Given this list of marker genes CGN, ARL8A, JMY (NCBI Gene Id 23651), MDM1, CLIP3, FTCD, KIF16B, TTLL6, KIF22, TTLL11, ARHGEF2, GAS2, DRG1, TTLL4, SPAG8, KLC3, MAP10, AGBL5, LRRK2, DNAL1, MAP9, MAPRE2, RGS14, TUBGCP6, TTLL9, HAUS8, FAM161A, FEZ1, WASH3P, MAP4K4, CEP350, TRIM36, APC, EML1 (EMAP like 1), ARL3, CCSER2, KIF14 (NCBI Gene Id 9928), KIF7, CFAP157, RPS3, KIF4A, MACF1, VPS41, DIP2B, IFT81, CHP1, KIF1B, KIF19, DNM1L, TTLL2, DNM3, AGTPBP1, EFHC1, MARK4, TUBGCP3, UNC5C, MAP7D2, KIF25, POLB, KIF3B, CCT5, TAOK1, HSPH1, TPPP2, CEP290 (centrosomal protein 290), BLOC1S2, MAST1, KIF26A, CENPE, CCDC187, APC2, SPIRE1, BRSK1, TTLL7, WDR90, CAMSAP3, TPGS1, DCTN1, NEIL2, KIF23, KIF21B, WHAMM, DLGAP5, ABRAXAS2, CCDC66, SSNA1, SGIP1, STMN4, NDRG1, RCC2, KIFC3, HAUS4, KIF20B, RP1, RMDN2, KIF4B, CCSAP, GABARAP, CEP57L1, CLIP2, RAD51D, KIF21A, AGBL1, TBCEL, MAP1B, SUN2, HDGF, CAPN6, ARL8B, MX2, SLC6A2, EML3, GJB6, CETN3, SKA1, NEFM, PHF6, FES (NCBI Gene Id 2242), TTLL13, RABGAP1, SPAG5, KATNBL1, GOLGA2, MTUS1, GAS2L3, EML2, TRPV4, KATNA1, FYN, HTT, GABARAPL1, APPL1, EMD, ZNF207, SPAST, FBXW11, TTLL1, WASH6P, CCDC61, FHDC1, KIF2A, VASH2, EML4 (EMAP like 4), CAMSAP1, KIF17 (NCBI Gene Id 57576), RANBP10 (NCBI Gene Id 57610), BRCA2, EML5, OPA1, GAS2L1, TPPP3, KIF27, BCL2L11, TTLL5, KIF1C, VAPA, DNM1, HOOK2, KIF2B, B9D2, SNCA, SETD2, KNSTRN, SPACA9, PRUNE1, WIPF3 (NCBI Gene Id 648464), CCDC88A, TUBGCP5, PLK1, CDK5R1, KIF13A, NEDD1, NIN, CCDC88C, FSD1, PAK1, EML6, SPMIP6, NME8, GJA1, RAE1, SPATA4, RMDN1, B4GALT1, MAPRE3, TUBGCP4, KIF1A, NDC80, IFT74, CENPJ, KIF11, GTSE1, PRNP, NUSAP1, KIFC2, KIF28P, PPP5C, JAKMIP1, NCALD, MX1, KIFC1, FAM110C, TRAPPC14, CLIP1, SBDS, SYT11, MAP1LC3B2, STMN1, NUMA1, DLEC1, KIF15, HOOK3, CRIPT, KATNAL2, PPP1R42, TPR, MAP1S, IRAG2, EZR, BCCIP, ARL4C, BEX4, TUBGCP2, S100A8, CETN1, CCDC88B, KIF9, PDE4B, CCDC170, KATNB1, TBCE, ALDOA, KIF6, VBP1, MAPT, STMN3, GIT1, DIAPH3, TERF1, ARHGEF7, CIMAP3, GLI1, SVBP (small vasohibin binding protein), KATNAL1, DYRK1A, KIF26B, TBCB, MID2, HDGFL3, STARD9, PSRC1, DDX3X, CENPF, KIF20A, TBCC, ADNP, RMDN3, SPAG6, BBS4, TOGARAM2, TPPP, UXT, MTUS2, INO80, CDK5, SMC3, TBCA, MAP4, ATF5, DST, KIF18A (kinesin family member 18A), PRKN, NEFH, CCDC181, KIF5A, TRAF3IP1, PEX14, AGBL2, HAUS7, CAV3, RAB11FIP5, TOGARAM1, SPC24, DNAI7, STIM1, HOOK1, CEP70, RACGAP1, ENKD1, KIF3A, FMR1, STMN2, REEP4, JAKMIP2, MAP1LC3A, KIF12, NEFL, VAPB, MAST2, FGF13, TBCD, PAFAH1B1, MAPRE1, CFAP144, REEP1, LRPPRC, CAMSAP2, KIF24, MAP1A (microtubule associated protein 1A), DIXDC1, SAXO2, MACO1, CLIP4, CRYAB, NDEL1, GAS8, FAM83D, SKA2, STRBP, NLRP5, NDN, CLASP1, CEP57, PACRG, KIF18B, CETN2, SPEF1, NAV3, HDAC6, CACYBP, FMN1, TTBK2 (NCBI Gene Id 26044), AGBL4, CKAP5, DCLK2, MAP1LC3B, ABRAXAS1, WASHC1, KIF3C, RGS2, CLASP2, REEP3, MAP2, OFD1, RAB11A, LUZP1, MID1, GABARAPL2 (NCBI Gene Id 90769), GAS2L2, LRRC61, LYN, BCAS3, DYNC1I1, KIF2C, PDCD5, TRIM54, REEP2, S100A9, DAG1, SAXO1, RITA1, BIRC5, GAPDH, NDE1, PADI6, KIF13B, DNM2, SPIRE2, KNL1, KRIT1, SKA3, MAP7D3, NUF2, DCDC1, MTCL1, CEP44, CEP135, CCDC69, CDK5RAP2, DCX, OGG1, MAP6, KIF5C, MAP6D1, CEP295, FNTA (farnesyltransferase, CAAX box, subunit alpha), KIF5B, AGBL3, JAKMIP3, PRC1, BRCA1, HAUS6, here is a description of the gene set: Binding to monomeric or multimeric forms of tubulin, including microtubules. Human Gene Set: GOMF_TUBULIN_BINDING species: Homo sapiens